The following is a description of a gene set: Enables the transfer of a solute or solutes from one side of a membrane to the other according to the reaction: CoQH2 + 2 ferricytochrome c = CoQ + 2 ferrocytochrome c + 2 H+. species: Mus musculus Mouse Gene Set: GOMF_UBIQUINOL_CYTOCHROME_C_REDUCTASE_ACTIVITY, and this is the list of marker genes: Uqcrfs1, mt-Cytb, Uqcrh, Cyc1, Uqcrh-ps1